The following is a description of a gene set: Human Gene Set: GOBP_REGULATION_OF_NATURAL_KILLER_CELL_PROLIFERATION species: Homo sapiens Any process that modulates the frequency, rate or extent of natural killer cell proliferation., and this is the list of marker genes: HLA-E, TYK2, PTPN22, JAK2, STAT5B, IL23A, RPL13A, IL18, LEP, IL15, IL23R, FCGR3A, IL12B, FLT3LG